The following is a description of a gene set: species: Mus musculus Genes predicted to be targets of miRBase v22 microRNA mmu_miR_652_5p in miRDB v6.0 with MirTarget v4 prediction scores > 80 (high confidence targets). from publication Chen Y, Wang X (PMID 31504780) Mouse Gene Set: MIR_652_5P, and this is the list of marker genes: Slc22a8, AA467197, Haus2, Rbbp8, Tspan9, Neurl1a, Top1, Gpm6b, Ammecr1l, Rsl24d1, Patz1, Epb41l2, Kat6b, Abhd17c, Rnf13, Coq5, Zfp317 (NCBI Gene Id 244713), Unc79, Cacnb3, Kpna1, Fem1a, Cyp2c65 (NCBI Gene Id 72303), B3galt1, Gramd2b, Spag9, Nrbf2, Topbp1, H2-M10.6, Snapin, Tcp11l2